The following is a description of a gene set: electronically inferred by orthology from the curated human pathway part of: Assembly of the pre-replicative complex Reactome Pathway: Assembly of the ORC complex at the origin of replication This event has been computationally inferred from an event that has been demonstrated in another species.<p>The inference is based on the homology mapping from PANTHER. Briefly, reactions for which all involved PhysicalEntities (in input, output and catalyst) have a mapped orthologue/paralogue (for complexes at least 75% of components must have a mapping) are inferred to the other species. species: Mus musculus, and this is the list of marker genes: Orc4, Kpna1, Kpna6, Orc5, Orc1, Kpnb1, Orc3